The following is a description of a gene set: Human Gene Set: MODULE_313 species: Homo sapiens Genes in the cancer module 313., and this is the list of marker genes: AHNAK, ZNF266, PLEKHA1, AP2A1 (NCBI Gene Id 92649), COA8, NUP107, NEUROD6, MGA, CACNG4, NUDT22 (nudix hydrolase 22), INTS11, WWC3, PTGIS, IGHM, ZNF185, EVI2B, CRYZL1, RGS5, IGLJ3